Given this list of marker genes ATP1B2, LRRC55, P2RX7, IFNG, FGF13, EDNRA, LRRC52, TMSB4X, FXYD6P3, WNK3, HTT, FHL1, AKAP6, CD19, CXCL11, P2RX4, STAC3, FLNA, SNCA, CAPN3, KCNJ2, NTSR1, ADCYAP1R1, DRD1, KCNN4, AMIGO1, KCNH2, TRPC6, CXCR3, THY1, CFTR, KCNC2, LCN2, JPH2, SCN1B, BAX, STAC2 (NCBI Gene Id 342667), TESC, BAK1, PPP3CC (protein phosphatase 3 catalytic subunit gamma), PLA2G1B, ABL1, LRRC26, GRIN1, AKAP5, TOR2A, HAP1, GAL, LRRC38, FXYD1, MIR1-1, CRACR2A, F2R, EDN1, TCAF1, STAC, NPSR1, P2RX3, CD4, F2, AKAP7, STIM2, ATP2A1, KCNE5, FXYD3, KCNC1, VMP1, WNK2, NIPSNAP2, EDN3, FXYD2, P2RX2, CXCL10, LACRT, GALR2, P2RX5, STIMATE, G6PD, NOS1, TRPC3, APLNR, CEMIP, CACNB2, GSTO1, ANO6, STK39, ATP1B3, ATP1B1, P2RX1 (purinergic receptor P2X 1), GPER1, P2RY6, NPPA, KCNIP2, PDPK1, HEPH, MS4A1, OPRK1, FXYD7, CXCL9, FXYD6, TRPC1, BDKRB1, MIR210, CTSS, FXYD4, PPP3CA, GRM6, KCNQ1, ACTN2, CX3CL1 (NCBI Gene Id 6376), CASQ1, ASPH, COX17, STIM1, F2RL3, XCL1, IL13, PPP3R2, CHP1, MIR21, ATPSCKMT, PPP3R1, FXYD5, SRI, PLCG1, KCNE1, ANK2, NOS1AP, CAV1, CACNB3, ACTN4, PPP3CB, here is a description of the gene set: Human Gene Set: GOBP_POSITIVE_REGULATION_OF_MONOATOMIC_ION_TRANSMEMBRANE_TRANSPORT Any process that activates or increases the frequency, rate or extent of the directed movement of ions from one side of a membrane to the other. species: Homo sapiens